The following is a description of a gene set: species: Homo sapiens p38 mitogen-activated protein kinase (MAPK) belongs to a highly conserved family of serine/threonine protein kinases. <p>The p38 MAPK-dependent signaling cascade is activated by pro-inflammatory or stressful stimuli such as ultraviolet radiation, oxidative injury, heat shock, cytokines, and other pro-inflammatory stimuli. p38 MAPK exists as four isoforms (alpha, beta, gamma, and delta). Of these, p38alpha and p38beta are ubiquitously expressed while p38gamma and p38delta are differentially expressed depending on tissue type. Each isoform is activated by upstream kinases including MAP kinase kinases (MKK) 3, 4, and 6, which in turn are phosphorylated by activated TAK1 at the typical Ser-Xaa-Ala-Xaa-Thr motif in their activation loops.<p>Once p38 MAPK is phosphorylated it activates numerous downstream substrates, including MAPK-activated protein kinase-2 and 3 (MAPKAPK-2 or 3) and mitogen and stress-activated kinase-1/2 (MSK1/2). MAPKAPK-2/3 and MSK1/2 function to phosphorylate heat shock protein 27 (HSP27) and cAMP-response element binding protein transcriptional factor, respectively. Other transcription factors, including activating transcription factor 2, Elk, CHOP/GADD153, and myocyte enhancer factor 2, are known to be regulated by these kinases. Reactome Pathway: activated TAK1 mediates p38 MAPK activation part of: MAP kinase activation, and this is the list of marker genes: UBB, IRAK1, IRAK2, MAPK14, TAB2, TRAF6, MAPK11, RIPK2, MAP2K6, UBE2N (NCBI Gene Id 7334), UBA52, NOD1, MAPKAPK3, UBE2V1, MAP2K3, RPS27A, IKBKG, MAPKAPK2, NOD2, UBC, TAB1, MAP3K7, TAB3